The following is a description of a gene set: Any process that modulates the rate, frequency or extent of a response to type II interferon (interferon-gamma). Response to interferon gamma is a change in state or activity of a cell or an organism (in terms of movement, secretion, enzyme production, gene expression, etc.) as a result of an interferon-gamma stimulus. Mouse Gene Set: GOBP_REGULATION_OF_RESPONSE_TO_TYPE_II_INTERFERON studied in species Mus musculus, and this is the list of marker genes: Hpx (NCBI Gene Id 15458), Pparg, Cdc37, Ptpn2, Txk, Parp14, Igtp, Arg1, Med1, Dnaja3, Nlrc5, Irgm1, Parp9, Irgm2, Otop1